The following is a description of a gene set: species: Homo sapiens Phenylalanine hydroxylase (PAH) normally catalyzes the conversion of phenylalanine to tyrosine. In the absence of functional PAH, phenylalanine accumulates to high levels in the blood and is converted to phenylpyruvate and phenyllactate. The extent of these conversions is modulated by genetic factors distinct from PAH, as siblings with the identical PAH defect can produce different amounts of them.<p>Both L-amino acid oxidase and Kynurenine--oxoglutarate transaminase 3 can catalyze the conversion of phenylalanine to phenylpyruvate and lactate dehydrogenase can catalyze the conversion of the latter molecule to phenyllactate, in reactions not annotated here. part of: Diseases of metabolism Reactome Pathway: Phenylketonuria, and this is the list of marker genes: PAH